Given this list of marker genes ACTC1, PPP1R13L, TNNI3, MYL2, MYBPC3, LMOD2, VCL, SCO2, TPM2, SMPX, PRKAG2, ACTN2, here is a description of the gene set: Human Gene Set: HP_MYOFIBER_DISARRAY A nonparallel arrangement of cardiac myocytes. Myofiber disarray species: Homo sapiens